The following is a description of a gene set: studied in species Homo sapiens Genes predicted to be targets of miRBase v22 microRNA hsa-miR-155-3p in miRDB v6.0 with MirTarget v4 prediction scores > 80 (high confidence targets). from publication Chen Y, Wang X (PMID 31504780) Human Gene Set: MIR155_3P, and this is the list of marker genes: HNRNPK, POU2AF3, SNX18, ZNF790, DYNC1I2, STX12 (syntaxin 12), PRKAR2B (protein kinase cAMP-dependent type II regulatory subunit beta), FAM156B, TXK, MYOT, PLEKHA5, PTPN21, SYT14, CRPPA, EDIL3, PIP4K2B, MGAT5, RNF4, DRP2, EBF2, CREBRF, MAPK14 (mitogen-activated protein kinase 14), OXR1, FGF12, ZNF629, HECTD4 (HECT domain E3 ubiquitin protein ligase 4), B4GALNT1, GJB6, POGLUT1, INPP5F, PEX5, VHL, EPAS1, ZNF737, TET2, PICALM, GPBP1, LSM14A, SERTAD2, ULK2 (NCBI Gene Id 9706), HNRNPF, KIF26B (NCBI Gene Id 55083), METTL9, RAB3C, SEC62, SYPL1, TBL1XR1, FABP2, ZFAND5, GNAI3, CEP70, NOG, GOLM1, ZBTB20 (NCBI Gene Id 26137), SMIM7, CYBRD1, AK9, FAM156A, SNTB1, SOX30, MRPS6, ARMC2, FER, CEP350, DENND1B, DPYSL2, CELF4, SMAD5, PCP4, HTR2C, RERE, RAPGEF4, SPTA1, SMAP1, TNPO1, ZNF575, RFC3, ARHGEF33, SMAD4, PHLDA1, IDO1, VGLL4, OSBPL10, ZBTB41, PPM1A, HIRA (NCBI Gene Id 7290), EAF1, UNK, DDX31, TRIP12, TSHZ1, LSM14B, SLC25A3